Given this list of marker genes Mfsd2b, Mthfr, Trbv2, Nol4, Nacc1, Acad11, A830073O21Rik, Snora17, Gm26447, Nt5c, Dpy19l1, Sass6, Zc3h14, Ccdc85a, Snph, 2500004C02Rik, 9530082P21Rik, Wnk1, Gm23369, Ddx47, Inpp5f, Abr, Gsk3b, Sema4d, S100a14, Tdrp, Anks1b, Ovca2, Mapkbp1, Hapstr1, Rxrg, Rad23b, St6galnac4, Mir7b, Vstm2a, Hpca, 5031434O11Rik, Pcyox1, Ankrd46, Ttll6, Gm24161 (NCBI Gene Id 115486256), Klhl15, Gm12125, Stag1, Gm6341, Rian, Ankrd13c (ankyrin repeat domain 13c), Rassf1, Ctbs, Gnl3, Metap2, Adam33, Cltc, Rpl30-ps6, Shmt1, Gpn2, Khdc3, Srrm3os, Lpar2, Mta2, Cyb5r4, Cbr1, Slc25a42, C2, Gm19088, Dtnb, Snord83b, Slc39a3, Hsph1, 5430400D12Rik, Tmem131, Rnf149, Gm18182, Gpn3, Exosc2, Ttbk1, Snord49b, Grin1os, Tcfl5, Trmt1, Sag, Kdm5b, Gm12826, Got1, Nubp1, Pacsin2, Lonrf3, Myo1h, Kdm5a, Smg7, Mllt11, Gm26479, Snora81, Nav3, Chordc1, Ubac1, Chn1, Inip, Mir196a-2, Tceanc2, Ppp4r3a, Zic1, Suox, Mir1199, Actb, Arhgap27os1, Mir7217, Zfp280b, Gm18553, Calm1, Efna3, 9430015G10Rik, Polr3g, Chka, Rock2, Ywhaz, Gm12089, Pgk1, C130036L24Rik, Glyatl3, Fpr3, Gm19552, Ndufa1, Poll, Pgls, Gak, Gm26078, Iqch, Lage3, Mir1938, Gm7429, Zdhhc17, Adnp, Traf7, Mdk, Kcnma1, Gm13270, Ap3s2, 4930577N17Rik, Usp1 (ubiquitin specific peptidase 1), Klhl32, Npw, Mtg2, Pea15a, Tmem208, Tomm40, Cenpa, Gm22766 (predicted gene, 22766), Pate2, Cflar, Pfkfb3, Mien1, Fblim1, Ramp1, Phf19, Bax, Dpy19l4, Kcnc1, Spg11, Thumpd3, Prrc2c, Fam216a, Rsu1, Ifrd1, Nif3l1, Alox12e, Mir7668, Snx5, Neurod4, Terf2, Gstp2, Nipbl, Gtf2ird1, AW554918, Arhgef17, Srpk1, Primpol, Gm12874, Ywhag, Slc39a9, Zwint, Nkx1-2, Igkv8-21, Prune2, Gm34106, Mecom, Zfp143, Adipor2, Vps16, Gtf2a1, Slitrk5, Ppib (NCBI Gene Id 19035), Impdh1, Baz1b, Mrm3, Ube2i, Mgme1, Fermt1, Pkib, Eif2b3, Lin52, D430040D24Rik, Gm14066, Tmem179, Ints7, Mpped2 (metallophosphoesterase domain containing 2), Mpzl2, Cacnb4, C1qbp, Gm12828, Glra1, Epha1, Ino80d, Kmt2d, Inhbe, Lrp11, Prorsd1, Gm19705, Mir2861, Zhx2, Cadm2, Mbd5 (NCBI Gene Id 98951), Ndrg3, Sh3kbp1, Csgalnact1, Top2a, Tmem242, Mir7024, Gfra2, Sergef, Abtb3, Gm7008, Gm20257, Zfp27, Mmp24os1, Kcnab3, Dnaaf9 (NCBI Gene Id 98941), Pfkp, Fkbp3, Mxd3 (NCBI Gene Id 17121), Aldh6a1, Septin9, Rnf138rt1, Gm19721, Zcchc17, Lrrc72, Gm16096, Gm15784, Eif1ad, Prdx1, Atrip, Frmpd1, Rnf215, Ppp2r2b, Carhsp1, Scp2 (NCBI Gene Id 99990), Panx1 (NCBI Gene Id 55991), Shisa5, Gm24201, Gdi1 (GDP dissociation inhibitor 1), Sec61a2, Lrp8, 6330562C20Rik, Isg15, Erh, Smpd1, Mapk8ip2, Entrep3, Mrpl14, Hes2, Rnf220, Dpcd, Zc3hc1, Aagab, Jdp2, Mafg, Eml1, Acap1, Rab12, Gas2, Spata32, Eml6 (NCBI Gene Id 73111), Gm4349, Irak3, Akap13, Peli1 (NCBI Gene Id 77964), Tsc2, Zfp689, Hcrtr2, Bahcc1, Trim28, Gm6116, Eif4a2, Anapc15, Spmip10, Atrn, Caprin2 (NCBI Gene Id 232560), Caskin2, Ddx59, Setd4, Slco2a1, Ociad1, Chic2, Gm11945, Tll1, Mrps25, Gm12608, Nop58, 3010001F23Rik, Tspan9, Nap1l3, Sec24b, Crb2, Samd10, Ankrd9, Pax5, Ccnb1 (NCBI Gene Id 268697), Mki67 (antigen identified by monoclonal antibody Ki 67), Ncaph, Ubtd1, Igbp1, Zc3h11a, Rpp25, Fancc, Scg3, Gm24536, Wdr70, Tmigd3, Gm14122, Gsc2, Mrps22, Cpz, Klc4, Atp6v0a1, Gm22806, Mrm2, Mir219c, Ctnna3, Mcf2l, Sinhcaf, Tpm1, Arhgap4, Adamtsl5, Pot1a (protection of telomeres 1A), Zbtb7a, Mir6405, Trbv31, Atp2b1, Sntg1, Gm8098, Pask, Tsnax, Nudt1, Ufd1, Fbll1, Hcst, Atxn7l1, Mblac2, Cenpm, Ap2a1, Pcif1, Ppil3, Mir3960, Def8, Tmem150b, 5730480H06Rik, Psmd13, Cc2d1b, Efna4, Pstk, Isoc2a, Rabif, Fchsd1, Dnajc25, Dhodh, Ptges3, Fam193a, Mfsd5, Chek2, Tram1, Hspbp1, Gtf3c6, Zbtb33 (NCBI Gene Id 56805), 1700126H18Rik, Afdn, Mrpl13, Grm6 (glutamate receptor, metabotropic 6), Pik3ap1 (NCBI Gene Id 83490), Sema4c, Cilk1, Mir338, Dkc1, Itgb2l, Arl4aos, Setd1a (SET domain containing 1A), Rpl19, Eef1a1, B3galt4, Six3, Med18, Cfap45, Nfkbil1, Cacng2, Ptges3l, Ptp4a1, Gm16102, Omg, Timm22, Odad1, Gm17546, Gm38411, Klhl5, Kif11, Vac14 (NCBI Gene Id 28016), Syngap1, Cdc45, Gm11362, Mtmr4, S1pr2, Myt1l, Gm16103, Klhl8, Rfx2, Col8a2, Zfp36l1, Brpf1, Olfm3 (NCBI Gene Id 229759), Otop2, Ttyh1, Or1j9-ps1, Mms22l, Zfp560, Fbxl9, Aars1, Lcor, Rtn4ip1, Cldn34a, Mrpl2, Necab3, Abca4, Gpr75, Senp6, Enox1, Atp6v1g2, Gm9916, Mir137, Hey1, Cfap100, Adprs, Kcna1, Nova1, Misp3, Sptlc2, Cst9, Rsl24d1, Bcas1, Efcab2, Crcp, Rnf123, Col5a3, Stab2, Hscb, Crim1, Ihh, Ccdc65, Gm26176, Ppfibp2, Pcgf3, Scrt1, Scn3b, Gm15897, Pbx2, Stk38l, Slc25a39, Slc27a2, Tsen54, Rnu11, Sort1, Srsf1, Ppa2 (pyrophosphatase (inorganic) 2), Casp3, Snhg7os, Gm12743, Spata3, 1700022N22Rik, Tubgcp3, Mir7070, Pten (NCBI Gene Id 70161), Tmem120b, Atxn3, Kif2c, Hlx, Tmbim4, Nfxl1, Ttc23l, Tor1aip1, Pax6, Slain1, Gprin1, Nhsl2, Amd-ps3, Gm13889, Thbs4, Csnk1d, Gm8398, Zfp62, Psma2, A430005L14Rik, Ubr7, Mbtps2, Lmo2, Mms19, Cfap251, Mtf2, Tie1, Tcf4, Napg, Gm11434, Asah1, Mybl2, Gm5700, Hbp1, Slc25a53, Copb1, Cnnm2, B4galt3, Vgll4, Sema4g, Disp2, Ppp1r21, Gatc, Cp, Ccnt1, Foxm1, 1110028F18Rik, Vim, Tor1aip2, Rfwd3, Rpl5, Mfsd4a, Capn15, Mest, Zfp438, Barhl1, Copb2, Snhg6, Park7, Car7, Eif4ebp2, H1f2, Gm8495, Echdc2, Taf1d, Clba1, Tut1, Eprs1, Snord45c, Gm17322, Mir7075, Exoc1, Apbb2, Ggta1, Rabggtb, Slc25a15, Ttf1, Fam43a, Banp, Cc2d1a, Pcdh1, Tsc22d1, Gm26871, Mrpl32, Marchf3 (membrane associated ring-CH-type finger 3), Ip6k1, Pus1, Tnrc6a, Spred1, Mis18bp1, Gmeb1, Arpin, 2210016L21Rik, Fut9, Tnk2, Hilpda, Fubp3, Rnaseh1, 4930579K19Rik, Cacng3, Satb2 (NCBI Gene Id 212712, special AT-rich sequence binding protein 2), Orc4, Ahcyl2, Rbmxl2, Mir6347, Capns1, Pde4d, Hsp90ab1, Nr5a2, Trim3, Smarcal1, Cyth2, Rpl27a, Pik3r2, Usp48, Nedd8, Dazl (deleted in azoospermia-like), Chga, Ring1, Zc3h18, Mir1192, Gm24313, Ankrd53, Sirt3, Ush1g, 4731419I09Rik, Ankrd40, Prss50, Cep295nl, Cartpt, Bicdl1, Selenop, Wnt6, Chfr, Prdx6, Mir210, Tmem42, Ino80dos, Zfp827, Plcl2, Snord49a, Glod4, Mir26a-2, Asxl1, Gpr143, Mtbp, Ablim2, Mroh7, Ago3, Pcdhga7, Pcnx3, Cdk9, Mir3073a, Ubald1, Rprd2, Fam184a, Clcn6, Akirin1, 9330151L19Rik, Hs3st1, Gm16069, Ctdsp2, Banf1, Snhg17, Gm12602, Speg, Arl4a, Yipf2, A730017L22Rik, Cdh1, Fcgr2b, Gmpr2, Dennd4c, Gm11528, Cbln1, Hes1, Aptx, Fcgr3, Fas, Mars2, Cpeb3, Zfp788, Agap1, Anapc5, Prrc2a, Homer1, Msh4, Mdc1, Bclaf3, Cdc16, Ythdc1, Dus2, Pja1, Fryl, Cd164, Zfta, A230083N12Rik, here is a description of the gene set: from publication Yevshin I, Sharipov R, Kolmykov S, Kondrakhin Y, Kolpakov F (PMID 30445619) species: Mus musculus Genes containing one or more binding sites for (Zfp985_UNIPROT_Q5U4F7_UNREVIEWED) in their promoter regions (TSS -1000,+100 bp) as identified by GTRD version 20.06 ChIP-seq harmonization. Mouse Gene Set: ZFP985_UNIPROT_Q5U4F7_UNREVIEWED_TARGET_GENES